The following is a description of a gene set: Any process that activates or increases the frequency, rate or extent of protein K63-linked ubiquitination. Human Gene Set: GOBP_POSITIVE_REGULATION_OF_PROTEIN_K63_LINKED_UBIQUITINATION studied in species Homo sapiens, and this is the list of marker genes: PTPN22, NOD2, RIPK2, DDX3X, UBE2N, UBE2V1, BIRC2, UBE2V2